The following is a description of a gene set: Corneal stromal edema species: Homo sapiens Abnormal accumulation of fluid and swelling of the stroma of cornea. Human Gene Set: HP_CORNEAL_STROMAL_EDEMA, and this is the list of marker genes: OVOL2, GRHL2, LTBP2, TGFBI, CPAMD8, PDGFRB (platelet derived growth factor receptor beta, NCBI Gene Id 5159), COL8A2, MYOC, ZEB1, TEK, CYP1B1, SLC4A11, VSX1, TCF4